The following is a description of a gene set: A single cancer cell contains large numbers of genetic alterations that in combination create the malignant phenotype. However, whether amplified and mutated genes form functional and physical interaction networks that could explain the selection for cells with combined alterations is unknown. To investigate this issue, we characterized copy number alterations in 191 breast tumors using dense single nucleotide polymorphism arrays and identified genes with copy number gain organized into 30 amplicons. Amplicons were distributed unequally throughout the genome. Each amplicon had distinct enrichment pattern in pathways, networks, and molecular functions, but genes within individual amplicons did not form coherent functional units. Genes in amplicons included all major tumorigenic pathways and were highly enriched in breast cancer-causative genes. In contrast, genes with somatic mutations in breast cancer were distributed randomly over the genome, did not represent a functionally cohesive gene set, and were relatively less enriched in breast cancer marker genes. Mutated and gained genes did not show statistically significant overlap but were highly synergistic in populating key tumorigenic pathways including transforming growth factor beta, WNT, fibroblast growth factor, and PIP3 signaling. In general, mutated genes were more frequently upstream of gained genes in transcription regulation signaling than vice versa, suggesting that mutated genes are mainly regulators, whereas gained genes are mostly regulated. ESR1 was the major transcription factor regulating amplified but not mutated genes. Our results support the hypothesis that multiple genetic events, including copy number gains and somatic mutations, are necessary for establishing the malignant cell phenotype. Human Gene Set: NIKOLSKY_BREAST_CANCER_7P15_AMPLICON Genes within amplicon 7p15 identified in a copy number alterations study of 191 breast tumor samples. species: Homo sapiens from publication Nikolsky Y, Sviridov E, Yao J, Dosymbekov D, Ustyansky V, Kaznacheev V, Dezso Z, Mulvey L, Macconaill LE, Winckler W, Serebryiskaya T, Nikolskaya T, Polyak K (PMID 19010930), and this is the list of marker genes: HOXA6, HOXA13, HOXA9, HOXA4, HOXA2, HOXA5, HOXA10, HOXA1, HOXA7, HOXA3, HOXA11